Given this list of marker genes PSMC5, PPP3CA, UBA52 (NCBI Gene Id 7311), PSMC6, PRKCB, PSMA6, IKBKB, PSMD3, PSMD14, BCL10, PSMB1, PSMD13, PSMA1, FKBP1A, PSMC4, BTRC, PSMB5, RELA, RPS27A, PSMA7, RASGRP1, PSMB3, NFATC3, NFATC2, PSMD7, PPP3CB, CARD11, PSMA4, PSMC2, HRAS, SEM1, PSMB6, NRAS, ADRM1, PSMD6, CALM1, PSMD1, PSMC3, CUL1, PPIA, NFKBIB, NFKBIE, PSMC1, PSMD12, RASGRP3, UBC (NCBI Gene Id 7316), PSMD2, CHUK, PPP3R1, PSMD8 (proteasome 26S subunit, non-ATPase 8), PSMA2, NFATC1, MAP3K7, FBXW11, PSMA3, PSMB2, PSMB4, IKBKG, PSMB7, NFKB1, MALT1 (MALT1 paracaspase), PSMD11 (proteasome 26S subunit, non-ATPase 11), UBB (NCBI Gene Id 91253), KRAS (NCBI Gene Id 3845), PSMA5, SKP1 (NCBI Gene Id 6500), NFKBIA, REL, here is a description of the gene set: studied in species Homo sapiens Second messengers (calcium, diacylglycerol, inositol 1,4,5-trisphosphate, and phosphatidyinositol 3,4,5-trisphosphate) trigger signaling pathways: NF-kappaB is activated via protein kinase C beta, RAS via RasGRP proteins, NF-AT via calcineurin, and AKT via PDK1. Reactome Pathway: Downstream signaling events of B Cell Receptor (BCR) part of: Signaling by the B Cell Receptor (BCR)